The following is a description of a gene set: This event has been computationally inferred from an event that has been demonstrated in another species.<p>The inference is based on the homology mapping from PANTHER. Briefly, reactions for which all involved PhysicalEntities (in input, output and catalyst) have a mapped orthologue/paralogue (for complexes at least 75% of components must have a mapping) are inferred to the other species. Reactome Pathway: Synthesis of IP2, IP, and Ins in the cytosol studied in species Mus musculus electronically inferred by orthology from the curated human pathway part of: Inositol phosphate metabolism, and this is the list of marker genes: Inpp4b, Inpp5j, Isyna1, Inpp5a, Inpp5b, Ocrl